The following is a description of a gene set: Human Gene Set: GOBP_POSITIVE_REGULATION_OF_DIGESTIVE_SYSTEM_PROCESS species: Homo sapiens Any process that increases the frequency, rate or extent of a digestive system process, a physical, chemical, or biochemical process carried out by living organisms to break down ingested nutrients into components that may be easily absorbed and directed into metabolism., and this is the list of marker genes: SCT, PRAP1, NEGR1, GHRL, GHSR, AQP1, OXT, SLC22A5, CYP8B1, LPCAT3, CRH, PPP3CA, NR1H2 (NCBI Gene Id 7376), ENPP7